The following is a description of a gene set: Mouse Gene Set: GOBP_REGULATION_OF_CELL_GROWTH_INVOLVED_IN_CARDIAC_MUSCLE_CELL_DEVELOPMENT Any process that modulates the rate, frequency, or extent of the growth of a cardiac muscle cell, where growth contributes to the progression of the cell over time from its initial formation to its mature state. species: Mus musculus, and this is the list of marker genes: Mtor, Rgs2, Zfp418, G6pdx, Yy1, Ep300 (NCBI Gene Id 328572, E1A binding protein p300), Nr3c1, Fdps, Cav3, Ddx39b, Ccn4, Ppara, Foxp1, Tomm70a, Dyrk1a, Sirt1, Rbm10, Edn1, Adrb1, Akap6, Slc25a4, Trip10, Pin1rt1, Gsk3a (glycogen synthase kinase 3 alpha), Rgs4, Hamp2, G6pd2, Hamp, Ctdp1, Pin1, Pak1, Parp2, Pi16, Col14a1, Igf1